Given this list of marker genes SLC46A3, SLC30A2, SLC48A1, SLC30A3, AP3D1, SLC15A4, SLC17A9, SLC30A4, MFSD1, here is a description of the gene set: studied in species Homo sapiens Human Gene Set: GOBP_VACUOLAR_TRANSMEMBRANE_TRANSPORT The process in which a solute is transported from one side of the vacuolar membrane to the other.